Given this list of marker genes IFNAR1, IFNB1 (NCBI Gene Id 3456), IFNA13, IRF7, IFNA16, STAT2, IFNA8, IFNAR2, IFNA21, STAT1, IFNA6, IRF9, EIF2AK2, TYK2, IFNA7, IFNA5 (NCBI Gene Id 89952), IFNA14, IFNA2, JAK1, IFNA4, IFNA10, IFNA17, IFNA1, here is a description of the gene set: Human Gene Set: KEGG_MEDICUS_REFERENCE_TYPE_I_IFN_SIGNALING_PATHWAY species: Homo sapiens Pathway Definition from KEGG: (IFNA,IFNB1) -> (IFNAR1+IFNAR2) -> (JAK1,TYK2) -> (STAT1+STAT2+IRF9) => (IRF7,EIF2AK2) Type I IFN signaling pathway. Pathway ID: N00150. Pathway type: Reference. Pathway class: nt06263 Hepatocellular carcinoma.